The following is a description of a gene set: from publication Chen C, Ouyang W, Grigura V, Zhou Q, Carnes K, Lim H, Zhao GQ, Arber S, Kurpios N, Murphy TL, Cheng AM, Hassell JA, Chandrashekar V, Hofmann MC, Hess RA, Murphy KM (PMID 16107850) Division of spermatogonial stem cells produces daughter cells that either maintain their stem cell identity or undergo differentiation to form mature sperm. The Sertoli cell, the only somatic cell within seminiferous tubules, provides the stem cell niche through physical support and expression of surface proteins and soluble factors. Here we show that the Ets related molecule (ERM) is expressed exclusively within Sertoli cells in the testis and is required for spermatogonial stem cell self-renewal. Mice with targeted disruption of ERM have a loss of maintenance of spermatogonial stem cell self-renewal without a block in normal spermatogenic differentiation and thus have progressive germ-cell depletion and a Sertoli-cell-only syndrome. Microarray analysis of primary Sertoli cells from ERM-deficient mice showed alterations in secreted factors known to regulate the haematopoietic stem cell niche. These results identify a new function for the Ets family transcription factors in spermatogenesis and provide an example of transcriptional control of a vertebrate stem cell niche. Genes down-regulated in Sertoli cells from both 4 and 10 week old ETV5 knockout mice. species: Mus musculus Human Gene Set: CHEN_ETV5_TARGETS_SERTOLI, and this is the list of marker genes: CD53, XIST, ANGPTL2, FCGR2A, CLEC7A, ARID3B, CCL7, CXCL12, FCGR2B, CCL15, GPNMB, MS4A6A, SYCP3 (synaptonemal complex protein 3), CD36, ARSB, IL6, CEMIP, KIDINS220, IGFBP4, MMP12, GCG, THBD, CXCL6, C1QB, PLEK (NCBI Gene Id 5341), ELAVL2